The following is a description of a gene set: Mouse Gene Set: GOBP_AXON_EXTENSION_INVOLVED_IN_REGENERATION Long distance growth of a single axon process involved in regeneration of the neuron. studied in species Mus musculus, and this is the list of marker genes: Lamb2, Tnr, D130043K22Rik, Ntrk3, Lrp1